Given this list of marker genes Skp2, Med1, Parp1, Foxa1, Ar, Ncoa3, Pagr1a, Wbp2, Pak1, Srarp, Kmt2d, Fshr, here is a description of the gene set: Any process that activates or increases the frequency, rate or extent of the activity of an intracellular estrogen receptor signaling pathway. species: Mus musculus Mouse Gene Set: GOBP_POSITIVE_REGULATION_OF_INTRACELLULAR_ESTROGEN_RECEPTOR_SIGNALING_PATHWAY